The following is a description of a gene set: Mouse thymocytes can be classified into four major subsets based on expression of CD4 and CD8 co-receptors. CD4-CD8- (double negative, DN) cells become CD4+CD8+ (double positive, DP) cells following productive T cell receptor (TCR) beta chain rearrangement. A small proportion of DP cells are selected through interaction of clonal TCRalpha/beta and MHC self peptide complex expressed on thymic stromal cells. DP cell expressing MHC class I-restricted TCR become CD4-CD8+ cells, which will finally differentiate into cytotoxic T cells, while MHC class II restricted selection generates CD4+CD8- helper lineage T cells. We used microarrays to identify genes important for thymocyte differentiation and lineage determination by profiling gene expression in different thymocyte subsets. Genes down-regulated in comparison of CD4+ CD8- thymocytes versus CD4- CD8+ thymocytes. Human Gene Set: GSE31082_CD4_VS_CD8_SP_THYMOCYTE_DN studied in species Homo sapiens from publication Egawa T, Littman DR (PMID 21873191), and this is the list of marker genes: FRRS1, TPST2, SLN, ZNF358 (zinc finger protein 358), SMAP2, PA2G4, ZDHHC16, MMP17, HCN3, MIDEAS, HAAO, SLC12A7, NXT1, HDAC4, XKRX, NUP107 (NCBI Gene Id 57122), KLHDC3, CHRD, PPP1R1B, RSAD1, POLR1G, CDC14B, PMEPA1, DPCD, BTG3, AGPAT5 (NCBI Gene Id 55326), PDSS1, CUEDC2, CRIP1 (NCBI Gene Id 1396), REEP1, SEC11C, IL2RB, EIF2A, B4GALT5, TRIM59, CENPM, CDT1, SLC43A2, PHB1, ENG, CRIPTO, HMGB1, HINT1, TMEM97, FAM111A, KRT16, PEAK1, RBMXL2, TDRP, WDR24, FAM78A, PKP4, BEX1, RPS5, SLC39A6, PPA1, KLF3, MEN1, TAMALIN, ACP5 (NCBI Gene Id 54), MTHFD1L, MCM6, RECK (reversion inducing cysteine rich protein with kazal motifs), GINS1, CDC42BPG, UHRF1, EVI2B, ARMCX4, ACP3, CABIN1, CENPH, FRMD4A, DRC1, CAD, HCST, KCTD9, COX18, MXD3 (NCBI Gene Id 83463), POU2AF1, SSB, TUBG1, HAUS8, PIDD1, SLC19A1, NELFE, BLM, CTSW, ATP8B4, EMID1, ITGB7, SELENOH, SRM, WDR77, DPP4 (dipeptidyl peptidase 4), PRADC1, PABPC4, FBXL8, BAG2, AHNAK, STX2, RFC2, TIMELESS, FAF1, BAZ1A, MANBAL, C4orf51, HTR2B, ELP3, PLP2, FEN1, SIKE1, MRPL20, EEF1D, EIF1AX, SORL1, ACACB, SLC45A1 (solute carrier family 45 member 1), AUNIP, MCTP2, ANAPC13, GRAMD4, CENPW, CDC6, SCARB1, GSTM5, BASP1 (NCBI Gene Id 10409), NOP56 (NOP56 ribonucleoprotein), DYNLT1, ANXA2, ATIC, RMI2 (RecQ mediated genome instability 2), SLC17A9, LINC01160, RAD23B, MICAL1, HRH3, RANBP1, TIGD5, RNASEH2B, B3GNT4, RELL1, TRIM14, FAM241A, RMND5B, TNFRSF13C, DEK, PREX2, ESYT1, MYL9, PKD1L2, GRIA3, GINS2, SCNM1, PRR22, CLEC4A, TSSK2 (testis specific serine kinase 2), SARAF, HID1, UMPS, BHMT, MAP1B, HELLS, CELF5, HTR1A, GOLM2, SMC1A, DHFR, NOD1, RUNX3, RFC4, ITGA4, TG, CCDC102A, PRF1, ZNF239, SNRPD1, STAT4, F2R, TDRD1, SPN (NCBI Gene Id 6693), SHQ1, EIF4EBP1, RARG, CD96, ADGRB2, SF3A2, SLAMF6, RCN1, MTFR2, BANK1, SAC3D1, NEFH, NEK6, LECT2, CENPQ, TDRD5, ZYX, ACSL5 (NCBI Gene Id 51703), APOC3